The following is a description of a gene set: Mouse Gene Set: GOCC_BCL_2_FAMILY_PROTEIN_COMPLEX studied in species Mus musculus A protein complex that consists of members of the Bcl-2 family of anti- and proapoptotic regulators. Bcl-2 proteins respond to cues from various forms of intracellular stress, such as DNA damage or cytokine deprivation, and interact with opposing family members to determine whether or not the caspase proteolytic cascade should be unleashed., and this is the list of marker genes: Bcl2, Pmaip1, Mcl1, Bcl2l2, Bcl2l11, Bak1, Bad, Bik, Bax, Bcl2l1